The following is a description of a gene set: A tooth which does not erupt within the teeth eruption timeline and after the loss of eruption potential. Human Gene Set: HP_ERUPTION_FAILURE species: Homo sapiens Eruption failure, and this is the list of marker genes: ZMPSTE24, FGFR1, PTH1R, TRIO (NCBI Gene Id 7204), APC, SMCHD1, SH3BP2, ANTXR1, FLNB, HOXD13, TCF4, IFIH1, LEMD2, CDH11, LMNA, MAP3K7, FLNA